The following is a description of a gene set: Human Gene Set: chr3p23 species: Homo sapiens, and this is the list of marker genes: ZNF860, GADL1, MIR466, ZNF587P1, CNN2P6, OSBPL10-AS1, THRAP3P1, RNA5SP127, STT3B, H3P11